The following is a description of a gene set: Reactome Pathway: Metabolism of Angiotensinogen to Angiotensins species: Homo sapiens part of: Peptide hormone metabolism Angiotensinogen, a prohormone, is synthesized and secreted mainly by the liver but also from other tissues. Renin, an aspartyl protease specific for angiotensinogen, is secreted into the bloodstream by juxtaglomerular cells of the kidney in response to a drop in blood pressure. Renin cleaves angiotensinogen to yield a decapaptide, angiotensin I (angiotensin-1, angiotensin-(1-10)). Circulating renin can also bind the membrane-localized (pro)renin receptor (ATP6AP2) which increases its catalytic activity. After cleavage of angiotensinogen to angiotensin I by renin, two C-terminal amino acid residues of angiotensin I are removed by angiotensin-converting enzyme (ACE), located on the surface of endothelial cells, to yield angiotensin II (angiotensin-2, angiotensin-(1-8)), the active peptide that causes vasoconstriction, resorption of sodium and chloride, excretion of potassium, water retention, and aldosterone secretion.<br>More recently other, more tissue-localized pathways leading to angiotensin II and alternative derivatives of angiotensinogen have been identified. Chymase, cathepsin G, and cathepsin X (cathepsin Z) can each cleave angiotensin I to yield angiotensin II. Angiotensin-converting enzyme 2 (ACE2) cleaves 1 amino acid residue from angiotensin I (angiotensin-(1-10)) to yield angiotensin-(1-9), which can be cleaved by ACE to yield angiotensin-(1-7). ACE2 can also cleave angiotensin II to yield angiotensin-(1-7). Neprilysin can cleave either angiotensin-(1-9) or angiotensin I to yield angiotensin-(1-7). Angiotensin-(1-7) binds the MAS receptor (MAS1, MAS proto-oncogene) and, interestingly, produces effects opposite to those produced by angiotensin II.<br>Aminopeptidase A (APA, ENPEP) cleaves angiotensin II to yield angiotensin III (angiotensin-(2-8)), which is then cleaved by aminopeptidase N (APN, ANPEP) yielding angiotensin IV (angiotensin-(3-8)). Angiotensin IV binds the AT4 receptor (AT4R, IRAP, LNPEP, oxytocinase).<br>Inhibitors of renin (e.g. aliskiren) and ACE (e.g. lisinopril, ramipril) are currently used to treat hypertension., and this is the list of marker genes: CES1, CTSZ, ENPEP, GZMH, ACE, MME, CTSD, REN, CMA1, CPB2, CPB1, CTSG, AGT, ATP6AP2, ANPEP, ACE2, CPA3